Given this list of marker genes HS3ST4, HS6ST1, HS3ST1, CHST7, NDST3, HS3ST3A1, HS6ST3, CHST9, CHST13, HS2ST1, HS6ST2, NDST4, NDST2 (NCBI Gene Id 8509), CHST14, CHST12, CHST3, CHST1, CHST8, CHST11 (NCBI Gene Id 55807), GAL3ST4, HS3ST6, HS3ST5, UST, HS3ST3B1, NDST1, HS3ST2, GAL3ST3, CHST6, here is a description of the gene set: Human Gene Set: GOMF_PROTEOGLYCAN_SULFOTRANSFERASE_ACTIVITY species: Homo sapiens Catalysis of the reaction: 3'-phosphoadenosine 5'-phosphosulfate + proteoglycan = adenosine 3',5'-bisphosphate + proteoglycan sulfate. A proteoglycan is a glycoprotein whose carbohydrate units are glycosaminoglycans.